Given this list of marker genes SMAD4, ACVR2B, INHBA, SMAD3, ACVR2A, ACVR1C, SMAD2, ACVR1B, here is a description of the gene set: Pathway Definition from KEGG: INHBA -> ((ACVR2A,ACVR2B)+(ACVR1B,ACVR1C)) -> (SMAD2,SMAD3) == SMAD4 Human Gene Set: KEGG_MEDICUS_REFERENCE_ACTIVIN_SIGNALING_PATHWAY Activin signaling pathway. Pathway ID: N01456. Pathway type: Reference. Pathway class: nt06507 TGFB signaling. species: Homo sapiens